Given this list of marker genes Ctnnb1, Apc, Inha, Atm, Mcm9, Tom1l2, Helq, Rint1, Lats1, Sav1, Smad4, Sptbn1, Cul9, Fancf, Foxo3, Htatip2, Bap1, Men1, Cdkn1b, Trp53, Trim37, Fshr, Pcsk6, Mcm8, here is a description of the gene set: species: Mus musculus from publication Motenko H, Neuhauser SB, O'Keefe M, Richardson JE (PMID 26092688) Mouse Gene Set: MP_INCREASED_OVARY_TUMOR_INCIDENCE Mouse genes annotated to increased ovary tumor incidence (MP:0008000) retrieved from the Mouse Genome Informatics database via MouseMine